Given this list of marker genes ANKRD37, TLCD2, KANSL1, TM9SF2, RFC1, EMC10, BBS12, GMFG, SP2-AS1, PRUNE1, GABPA, KCTD3, ACTR1B, MBLAC2, TRPC4AP, SESN1, RTN4IP1, L3MBTL3, TYSND1, WSB1, FAM50A, NDUFA3, CTDSP2, PRIMPOL, METTL13, DPY19L4, TTLL5, COQ8A, UTP3, CDKL3, FIGNL1, FLI1, EPRS1, CTBP2, ADCK1, PRDX4, VPS72, MRPS15, AIDA, MMADHC, PRIM1, ACTR8 (NCBI Gene Id 93973), DERA, DDI2, POLR2F, KLHDC3, MAP3K3, PACSIN2, HDHD2, PARP1, ZNF2, PLPP6, COQ3, POC5 (NCBI Gene Id 134359), METTL8, CTDSPL2, MBIP, PRPSAP1, TWF2, FRYL, UROS, ZNF133, POLR1H, PFKFB4, HMGN5, DNTTIP1, CHEK2, CARD19, TMEM9B, NDUFS8, SMG8, MARK3, ASAP2, TP53INP1, ZCCHC24, DCBLD1, TRIM33, MIGA1, KLHDC2, TMEM223, CCDC92, TRAPPC12, MTMR14 (myotubularin related protein 14), DOLK, NUDT6, TRAPPC5, ANKIB1, AGO4, VIPAS39, DNAJC28, ARHGEF6, NDUFA2, TMEM161B-DT, AREL1, GMPR2, CYB561D2 (NCBI Gene Id 11068), PCSK5, ZSCAN26, CYC1, DEF8, EXTL2, SPDL1 (spindle apparatus coiled-coil protein 1), CCP110, LYL1, RFX7 (NCBI Gene Id 64864), MAPK14, AP2S1, GTF2H2, EXOC1, KNTC1, ELF2, ARHGEF18, SMC2, DHRS4-AS1, ZNF283, HIBADH, DCAF10, NGDN, DSTYK, INPP4A, NAP1L4, NOA1, DAGLB, ACY1, SETDB1 (NCBI Gene Id 9869), CDADC1, GOLPH3, CUL4B, RNF167, CDCA7L, ZYG11B, RFC2, LOXL3, DNAJC14, PRIM2, IL17RA, PELI1, NR2C2, ZYX, NELFE, RBMX2 (NCBI Gene Id 51634), SPMIP4, CAD, WBP1L, SPRYD4, GSTCD, CETN2, SCAND1, PSD3, KLHDC1, VAMP8, CEP152, TMCO3, GPN2, CARD6, BBS1, MIS18A, ANAPC10, ABCA7, GIGYF2, TIMELESS, RNF113A, SLC25A14, ACSS2, MIA2 (MIA SH3 domain ER export factor 2), KIF22, MARCHF6, SFXN4, PELI2, LMLN, IMPA2, TOR1AIP1, ZNF879, HSF2, DENND6A (NCBI Gene Id 201627), EPS8L1, CTNNBL1, GAB3, DMAC1, TTC31, FPGT, SNX14, TFDP2, ZNF658, TFPT, DUSP11, ARMC8, CIAO1, PI4KA, TIGD2, NVL, CUEDC2, PLCL2, SLC2A4RG, SEC22A, MTMR2, GPR82, CHCHD5 (coiled-coil-helix-coiled-coil-helix domain containing 5), TALDO1, here is a description of the gene set: studied in species Homo sapiens Human Gene Set: GSE40666_STAT1_KO_VS_STAT4_KO_CD8_TCELL_UP Type 1 IFNs can conditionally activate all of the signal transducers and activators of transcription molecules (STATs), including STAT4. The best-characterized signaling pathways use STAT1, however, and type 1 IFN inhibition of cell proliferation is STAT1 dependent. We report that type 1 IFNs can basally stimulate STAT1- and STAT4- dependent effects in CD8 T cells, but that CD8 T cells responding to infections of mice with lymphocytic choriomenigitis virus have elevated STAT4 and lower STAT1 expression with significant consequences for modifying the effects of type 1 IFN exposure. The phenotype was associated with preferential type 1 IFN activation of STAT4 as compared to STAT1. Stimulation through the TCR induced elevated STAT4 expression, and STAT4 was required for peak expansion of antigen-specific CD8 T cells, low STAT1 levels, and resistance to type 1 IFN-mediated inhibition of proliferation. Thus, a mechanism is discovered for regulating the consequences of type 1 IFN exposure in CD8 T cells, with STAT4 acting as a key molecule in driving optimal antigen-specific responses and overcoming STAT1-dependent inhibition of proliferation. Genes up-regulated in CD8 T cells: STAT1 knockout versus STAT4 knockout. from publication Gil MP, Ploquin MJ, Watford WT, Lee SH, Kim K, Wang X, Kanno Y, O'Shea JJ, Biron CA (PMID 22968462)